Given this list of marker genes Kcne4, Ensa, Wnk2, Nedd4l, Kcnk2, Cav3, Wnk4, Wnk3, Wnk1, Cav1, here is a description of the gene set: Binds to and stops, prevents, or reduces the activity of a potassium channel. studied in species Mus musculus Mouse Gene Set: GOMF_POTASSIUM_CHANNEL_INHIBITOR_ACTIVITY